The following is a description of a gene set: studied in species Mus musculus Any process that modulates the frequency, rate or extent of matrix metallopeptidase secretion. Mouse Gene Set: GOBP_REGULATION_OF_MATRIX_METALLOPEPTIDASE_SECRETION, and this is the list of marker genes: Slc12a2, Rap1gds1, Ptger4, Tlr4, Tlr2, Bsg, Cd200, Idh2, Ifnb1